The following is a description of a gene set: Abnormal bleeding species: Homo sapiens An abnormal susceptibility to bleeding, often referred to as a bleeding diathesis. A bleeding diathesis may be related to vascular, platelet and coagulation defects. Human Gene Set: HP_ABNORMAL_BLEEDING, and this is the list of marker genes: AMACR, HLA-DPB1, IL12A-AS1, BLOC1S5, ANGPTL6, CALR, CDKN1A, RHBDF2, NFIA, USP18, CNTNAP2, NF1, TINF2, LRP5, STAT3, MSH2, XYLT2, UBAC2, RNF168, SF3B1, DOCK6, FGA, LMOD2, UBA2, WFS1, PTPN11, NTRK1, IL12A, HACE1, FANCA, SOS2, CCM2, ERCC8, F11, PLAU, RBM10, APOA1, DTNBP1, DIAPH1, HPS1, HLA-DRB1, SDHB, TBL1XR1, THSD4, C1S, P2RY12, BRAF, FIP1L1, HBA2, SRSF2, UFD1, STAT5B, CISD2, RANBP2, COG6, COPA, GSN, NEU1, NF2, USP8, SREBF1, PLCG1, MTAP, AKT1, SMARCB1, RFT1, EPHB4, BAP1, SMAD4, SMAD3, PROS1, POLE, THSD1, FAH, MPI, IFIH1, ITGB3, GP1BA, TLR4, PROC, NR3C1, LMO1, EFEMP1, STN1 (NCBI Gene Id 79991), CACNA1D, MGAT2, GP9, KANSL1, ACAD9, KCNJ5, MYD88, IVD, CYP7B1, HCK, MAP2K2, SLC25A11, RPS14, F13B, MSH6, ORAI1, PDGFRA, DSE, PEPD (peptidase D), PDGFRB, COG8, ATP6V1E1, PKHD1, MCFD2, FUCA1, F12, DLST, ZNFX1, ATP6V1A, SNX10, MARS2, SH2B3, CYP11B1, TGFBR2, MYLK, MMUT, RREB1, IL18BP, NUMA1, KRAS, ACTN1, THBS2, MYCN (MYCN proto-oncogene, bHLH transcription factor), CFHR1, LMAN1 (lectin, mannose binding 1), RS1, NEDD4L, POT1, ATM, SPARC, SLC35A1, CHEK2, SEC24C, PLEC, RB1, MFAP5, ATP7A, SAMD9, MRAS, FH, CEBPE, DOCK8, EPHB2, GREM1 (NCBI Gene Id 7947), DPP9, GAA, CFH, CCR1, DZIP1L, LYN, CYP11B2, F5, SNORD118, PMS2, FN1, FLNA, MMACHC, SLC2A10, FASLG, TNFRSF13C, SHARPIN, CTC1, GNA11, EPAS1, STT3A, TFR2, PDE11A, TAOK1, TNFSF12 (TNF superfamily member 12), SLC51A, BEST1, HSD3B7, CUBN, VWF, CDH23, SDHA, TGFB3, CBS, ITGB4, CASP10, ALG13, SLC25A13, HIRA, TSPAN12, G6PC1 (glucose-6-phosphatase catalytic subunit 1), ACP5, CST3, SCARB2, MYC, UNC13D, MPL, ZNF408, HPGD, MED12, AMN, F2, ENPP1, ENG, TREX1, TRAF7, USP48, FZD4, GP1BB, F7, UROS, XPR1, SDHD, RPS20, HELLPAR, PLOD1, GIMAP5 (GTPase, IMAP family member 5), LYST, F9, PRF1, ALDOB, CYSLTR2, ARHGAP31, BMS1, TCIRG1, SDHC, RASGRP2, SLC37A4, VHL, TBXA2R, MAPK1, LIN28B, MYORG, RIN2, STAT4, HOXA11, PRLR, HMOX1, XYLT1, SIK3 (SIK family kinase 3), CREB3L1, B4GALT1, ELMO2, PTEN, SOS1, FANCE (FA complementation group E), PTPRJ, HEY2, FKBP14, ACTA1, VPS33B, SERPINF2, COL4A2, DST, COL1A1, BRCA2, ITGA2, BRCC3, ITGA2B, SBDS, CD36, IKZF1, KIT (KIT proto-oncogene, receptor tyrosine kinase), MAX, ARF1, GATA2, RARA, CLCN7, MEN1, UROD, PMM2, C1R, PUF60, PCCB, DPAGT1, STX11 (NCBI Gene Id 8676), GCDH (glutaryl-CoA dehydrogenase), ATP8B1, HBB, ADA2, ETHE1, MLH1, F8, NLRC4, GDF2, F10, CDKN2B, COMT, GNAQ, TERC, LCP2, HPS5, ABCC6, LBR, TET2, OCLN, EMILIN1, AEBP1, MVK, GP6 (glycoprotein VI platelet), MDH2 (NCBI Gene Id 4191), ABCG8 (NCBI Gene Id 64241), DHPS, PRDM5, EIF2AK4, COL3A1, IFNGR1, FBN1, WAS, HPS6, TNXB, ESAM, LMNA, SUFU, PIK3CA, TGFBR3, MEFV, VKORC1, STAT2, STK11, NPM1, HPS3, CFHR3, MAP1B, SLFN14, GFI1B, APC, SPRED2, CTCF, ADAMTSL2, FCGR2C, NOTCH3, TEK, SMC5, CPT2, ZNF469, RASA1, SLC39A13, WIPF1, STXBP2, ARFGEF2, TP53, CHST14, MS4A1, TMTC3, COL5A2, STIM1, ARMC5, CDKN2C, RUNX1, STXBP1, ZBTB16, FGG, HMCN1, PRKCSH, EPCAM, LZTR1, TNFRSF13B, MUTYH, ZFX, RRAS2, COL4A1, ACVRL1, JMJD1C, TNFRSF1A, PHOX2B, KDM1A, ARVCF, FAS, FOXE3, SLCO2A1, NOTCH1, AIP (aryl hydrocarbon receptor interacting protein), APOLD1, P4HA2, RET, SMARCE1, PET100, PLVAP, SEC63, BLOC1S3, ACTA2, CFI, IKBKG, CD19, ETV6, MYH11, TSC2, KLKB1, PLOD3, HADHB, POLD1, NFKB1, PDGFB, PTPN22, SDHAF2, ATOH7, TGFB2, NDP, SRC, MAP2K1, EPOR (NCBI Gene Id 2057), RRAS, ANO6, TSC1, EOGT, ERAP1, PEX12, BCOR, SMO, ICOS, IKZF5, SIN3A, LAMB2, LOX, TNFSF11, JAK2, NBEAL2, ATP7B (NCBI Gene Id 540), FYB1, AGGF1, IRF4, ATRX, SP110, TMEM127, ERMARD, PDCD10, BGN, COL5A1, HLA-B, RYR1, TERT, TTC7A, GNA14, C4A, APP, FERMT3, B3GALT6, RACGAP1, CD109, GALE, RBM8A, TBX1, RBCK1, CR2, HBA1, HLA-DPA1, BICD2, PRTN3, CYP26C1, GNE (glucosamine (UDP-N-acetyl)-2-epimerase/N-acetylmannosamine kinase), ASXL1, TMEM237, ERCC6, THPO, IL10RA (NCBI Gene Id 3587), KIF23, SEMA4A, C2, GGCX, IL23R, RAF1, DCLRE1B, PRKAR1A, KIF1B, RIT1, ARL6IP6, RBPJ, ANKRD26 (ankyrin repeat domain containing 26, NCBI Gene Id 22852), NAGA, BMPR1A, IPO8, KLRC4, PMS1, ATP6V0A2, SLC7A7, CDKN1B, CAT (NCBI Gene Id 847), CLPB, NFKB2, RAB27A, CTLA4, DNM2, TGFBR1, GATA1, FANCD2, KRT1, CTNNB1, HPS4, ZMPSTE24, LMX1B, ARPC1B, SMAD2, NLRP3, JAM2, ARPC5, TPM4, APOE, FGB, NABP1, PCCA, NFIX, GNAS, MAT2A, CAPN5, FANCC, LMBRD1, AXIN1, SMPD1, ALK, IFNG, PML, PYCR1, MYH9, PRKACA, CD81, CBL, PDCD1, CD46, NRAS, ALPL, IRF2BP2, GBA1, NDE1, FLI1, DLL4, EXT2, PRKACG, ELN, SLC20A2 (solute carrier family 20 member 2), MYRF, DNMT3A, SERPINE1, AP3B1, IL10, ADAMTS2, LYZ, F13A1, RASA2, MTTP, COL1A2, KRIT1, PRKG1, CLCN2, ZEB2, CDC42BPB